The following is a description of a gene set: Mouse Gene Set: GOBP_PURINE_NUCLEOSIDE_DIPHOSPHATE_METABOLIC_PROCESS species: Mus musculus The chemical reactions and pathways involving purine nucleoside diphosphate, a compound consisting of a purine base linked to a ribose or deoxyribose sugar esterified with diphosphate on the sugar., and this is the list of marker genes: Pfkl (NCBI Gene Id 18641), Ncor1, Eno1b, Prxl2c, Pklr, Aldob, Gck, Hk3, Gpd1, Ins2, Eno1, Pfkm, Gapdh, Hkdc1, Ak3, Ak4, Mlxipl, Ak1, Pfkfb1, Entpd1, Uchl1, Bad, Entpd4 (ectonucleoside triphosphate diphosphohydrolase 4), Il3, Pgk2, Fbp1, Galt, Actn3, Ier3, Trim63, Ogdh, Hk1, Pkm, Trex1, Ppara, Pgam1, Pfkp, Nudt18, Nupr1 (nuclear protein transcription regulator 1), Nudt9, Enpp1, Insr, Sirt6, Fkrp, Aldoc, Gpi1, Gapdhrt2, Bcl2l13, Eno4, Aldoart2, Pals1 (NCBI Gene Id 70703), Mtor, Gale, Mfsd8, Prkaca, Slc4a4, Mpi, Flcn, Myc, Eno3, Entpd4b, Slc29a1, Ak2, Hdac4, Pgk1, Psen1, Ampd3, Pals2, Slc2a6, Foxk1, Ep300, Ppp2ca, Rptor (NCBI Gene Id 74370), Prkag2 (protein kinase, AMP-activated, gamma 2 non-catalytic subunit), Tpi1, Stat3, Myog, App, Ins1, Igf1, Dhtkd1, Slc4a1, Zbtb7a, Prkaa1, Eif6, Esrrb, Bpgm, Nt5e, Mlx, Pfkfb3, Prkag1, P2rx7, Pfkfb2, Prkaa2 (NCBI Gene Id 66516), Zbtb20, Lipa, Adpgk, Kat2b, Eno2, Prkag3, Aldoa, Arl2, Sik2, Mlst8, Jmjd8, Ucp2, Foxk2, Aldoart1, Khk, Ddit4, Galk1 (NCBI Gene Id 14635), Src, Pgam2, Ogt, Col6a1, Tigar, Ifng, Gapdhs, Mtch2, Tkfc, Hif1a, Guk1, Hk2, Gapdhrt, Entpd2, Ppargc1a, Htr2a, Cbfa2t3, Arnt, Git1